Given this list of marker genes PTGS2, IL10RB, TNFRSF1A, CCL5, IL10RA, CXCL1, CCR1, CXCL2, CCL20, CD80, IL12B, IL10, TYK2, IL1RN, CXCL10, CCL22, TNF, CSF2, CSF3, CCL4, CCL19, IL1R2, CCL2, IL1R1, PTAFR, CXCL8, IL12A, LIF, IL1A (NCBI Gene Id 3552), FPR1 (NCBI Gene Id 2357), IL1B, ICAM1, CSF1, TNFRSF1B, CCL3L1, TIMP1, JAK1, IL6, STAT3, FCER2, CCL3, CCR2, CD86, CCR5, IL18, here is a description of the gene set: part of: Signaling by Interleukins Interleukin-10 (IL10) was originally described as a factor named cytokine synthesis inhibitory factor that inhibited T-helper (Th) 1 activation and Th1 cytokine production. It was found to be expressed by a variety of cell types including macrophages, dendritic cell subsets, B cells, several T-cell subpopulations including Th2 and T-regulatory cells (Tregs) and Natural Killer (NK) cells. It is now recognized that the biological effects of IL10 are directed at antigen-presenting cells (APCs) such as macrophages and dendritic cells (DCs), its effects on T-cell development and differentiation are largely indirect via inhibition of macrophage/dendritic cell activation and maturation. T cells are thought to be the main source of IL10 (Hedrich & Bream 2010). IL10 inhibits a broad spectrum of activated macrophage/monocyte functions including monokine synthesis, NO production, and expression of class II MHC and costimulatory molecules such as IL12 and CD80/CD86 (de Waal Malefyt et al. 1991, Gazzinelli et al. 1992). Studies with recombinant cytokine and neutralizing antibodies revealed pleiotropic activities of IL10 on B, T, and mast cells (de Waal Malefyt et al. 1993, Rousset et al. 1992, Thompson-Snipes et al. 1991) and provided evidence for the in vivo significance of IL10 activities. IL10 antagonizes the expression of MHC class II and the co-stimulatory molecules CD80/CD86 as well as the pro-inflammatory cytokines IL1Beta, IL6, IL8, TNFalpha and especially IL12. The biological role of IL10 is not limited to inactivation of APCs, it also enhances B cell, granulocyte, mast cell, and keratinocyte growth/differentiation, as well as NK-cell and CD8+ cytotoxic T-cell activation. IL10 also enhances NK-cell proliferation and/or production of IFN-gamma. <br><br>IL10-deficient mice exhibited inflammatory bowel disease (IBD) and other exaggerated inflammatory responses indicating a critical role for IL10 in limiting inflammatory responses. Dysregulation of IL10 is linked with susceptibility to numerous infectious and autoimmune diseases in humans and mouse models (Hedrich & Bream 2010). <br><br>IL10 signaling is initiated by binding of homodimeric IL10 to the extracellular domains of two adjoining IL10RA molecules. This tetramer then binds two IL10RB chains. IL10RB cannot bind to IL10 unless bound to IL10RA; binding of IL10 to IL10RA without the co-presence of IL10RB fails to initiate signal transduction.<br><br>IL10 binding activates the receptor-associated Janus tyrosine kinases, JAK1 and TYK2, which are constitutively bound to IL10R1 and IL10R2 respectively. In the classic model of receptor activation assembly of the receptor complex is believed to enable JAK1/TYK2 to phosphorylate and activate each other. Alternatively the binding of IL10 may cause conformational changes that allow the pseudokinase inhibitory domain of one JAK kinase to move away from the kinase domain of the other JAK within the receptor dimer-JAK complex, allowing the two kinase domains to interact and trans-activate (Waters & Brooks 2015).<br><br>The activated JAK kinases phosphorylate the intracellular domains of the IL10R1 chains on specific tyrosine residues. These phosphorylated tyrosine residues and their flanking peptide sequences serve as temporary docking sites for the latent, cytosolic, transcription factor, STAT3. STAT3 transiently docks on the IL10R1 chain via its SH2 domain, and is in turn tyrosine phosphorylated by the receptor-associated JAKs. Once activated, it dissociates from the receptor, dimerizes with other STAT3 molecules, and translocates to the nucleus where it binds with high affinity to STAT-binding elements (SBEs) in the promoters of IL-10-inducible genes. species: Homo sapiens Reactome Pathway: Interleukin-10 signaling